Given this list of marker genes Pex1, Ubxn8, 4930591A17Rik, Srcin1, Sox13, Cdc42bpg, Esr2, Bloc1s6, Rnf13, Nemf, Slmap, Nus1, Cramp1, Ntm, Pdzrn3, Fam168a (family with sequence similarity 168, member A), Itga7, Gmnc, Zscan29, Pdk2, Mthfd2, Ifnar1, St3gal1, Il17a, Hbb-bs, Inka2, Calhm5, Hnrnpl, Atp1b3, Sv2c, Dhrs9, Fam222b (NCBI Gene Id 319557), Galnt13, 3110082I17Rik, Ptprm, Tmem169, Klhl15, Lrrc75a, Spock3, Nxn, Kctd6, Tfdp1 (NCBI Gene Id 21781), Gria3 (NCBI Gene Id 73036), Casp9, Ppm1k, Ginm1, Bbs9, Ctcf, Mmp25, Pdzd4, Cyp4f39, Cecr2 (NCBI Gene Id 76549), Cpne4, Gnrhr, Elovl2, Rfx5, Fam117a, Fgfr2, Dazl, Gabrg1, Sox21, Ssr2, Tcf7, Tshz3, Cops2, Reep3, Atf7, Lrrc8a, Rora, Vti1a, Zfp345, Spats2l, Flna, Csf1, Myrf, Orc4, Rgs4, Tyrp1, Cyb5d2, Hdgfl3, Eif4ebp2, Taf4b, Atrnl1, Strada, Adamts18, Msi2, Fbll1, Spag9, Stxbp5l, Chtf8, Osgepl1, Tlr12, Prx, Zfp148, Gspt1, Litaf, Yae1d1, Tesk1, Twsg1, Zfp704, Pcdh12, Camta1, Kirrel1, Ranbp10, Ppp2r3c, here is a description of the gene set: Mouse Gene Set: MIR_5710 species: Mus musculus Genes predicted to be targets of miRBase v22 microRNA mmu_miR_5710 in miRDB v6.0 with MirTarget v4 prediction scores > 80 (high confidence targets). from publication Chen Y, Wang X (PMID 31504780)